Given this list of marker genes ELMO1 (NCBI Gene Id 9844), ZBTB18, TMEM127, SOX4, GPA33, OGA, AZI2, KMT5A, GTSF1, IL23A, VPS4B, ARHGAP1, TMEM100, TBC1D17, NOSTRIN, PYM1, PCED1A, COPS7A, MAP2K6 (mitogen-activated protein kinase kinase 6), SIPA1, EGFL7, ESRRA, NCKAP1L, APBA3, PPP3CB, ZCRB1, ZCCHC9, EIF3L, WDR53, ANKHD1, DPP3, FAM200A, TIMMDC1, ZSCAN31, MRPL54, CFAP57, R3HCC1L, RXRB, CRTC2, NMNAT1, PRPF4, LIFR, TRAPPC1, RPL28, CAST, CORO6, ANKS1A, GABRA1, THAP5, PAF1, HELZ2, FOXN3, TMUB2, CES2, PAK3, DGKZ, ITPKB, LZTFL1, PCSK5, PDE12, PTPRG, TLE4, FYN, SLC39A7, DLG2, LINC03124, BTBD16 (BTB domain containing 16), OLFM1, CAPZA1, PPP1CA, VASP, MTBP, ZFP3, KANSL1, CPEB4, UBXN1 (UBX domain protein 1), RASAL1, MAP4K2, AP4E1, GIT2, ZNF35, LZTS2, RHOJ, LTB4R, TRAF7, ZRANB2, TBCC, TBC1D10C, ZNFX1, ARHGDIB, CHN2, INTS3, TEAD3, PDLIM5, GMPR2, RHOV, ANKHD1-EIF4EBP3, WDFY4, CHMP1B, WAS, SMC6, SLITRK1, MTX2, POU3F4, LCP1 (NCBI Gene Id 3936), CNTROB, EN1, TCF7, UQCRH, KLF12, CRB3, POLD4, CCNT1, PSMA5, STARD13, CREBZF, SHC1, CNST, SYTL1, STK10, PACC1, FAM110A, ST7L, PHB2, PRKAG2, FAM174A, FNTA (farnesyltransferase, CAAX box, subunit alpha), CCDC71, DPP8 (NCBI Gene Id 54878), EVX1, ELP2, IRF2BP1, FEZF2, FBXL9P, ZCCHC7, EPHA2, DOK1, EIF4G1, TIE1 (tyrosine kinase with immunoglobulin like and EGF like domains 1), MTPN, PPHLN1 (NCBI Gene Id 51535), TRPC4AP, IFI30, ARHGAP30, RBMS2, LLGL2, TMEM208, MAPK14, NEDD8, HERPUD2, ACKR1 (atypical chemokine receptor 1 (Duffy blood group)), DDX55, ZNF205, ARPC4, EIF3K, LCK, NOVA1, MCTS1, NUDT21, TRAPPC11, LOXL3, ELK3, TBX6, HERC4 (NCBI Gene Id 63907), ANKH, MTERF1, POMP, ZNF408, TMEM161B, CLN5, HAT1, U2AF2, LANCL3, VCL, VPS16, ADCY2, SLC39A11, LZIC, CCAR2, LYL1, RAP2C, UBE2D3, INSIG2, CITED2, CBLB, PHC2, AKT1S1, TAF5, UFC1, ARHGEF6, ZBTB7B, CSF3, PPIG, USE1, CKS1B, CNOT6L, DBR1, TADA3, DDX1, LDOC1, RAC1, ACIN1, RWDD4, CD37, PRDM1, STAT4, TFB2M, SEMA4C, EBNA1BP2, SOST, CCDC88B, RELCH, TXLNG, FURIN, MAP4K1, ZNF593, NECAP2, DNAJB9, VPS11, SOX15, PLEKHH2, DMTF1, MRPL13, ARHGEF4, BCL2L1, SASH3 (NCBI Gene Id 93952), NUP155, NUDT22, SEC11A, DCAF1, SLC39A6, EMG1, CIAO1, STX5, PAX6, ITGB7, PRKAB1, SNIP1, SP3, PTPRN, PPME1, TNNI2, TAGLN2, NKAIN1, UTP18, RTL9, CDC26, PLXDC2, NR1H2, NDN, SH2D3C, RBM6, GGNBP2, LINC01565, SIRPA, LSM5, DSCAML1, SH2D6, ZNF70, WDR90, GEN1, DGKA, ENPP1, ADNP, CIAO2B, TRPT1 (NCBI Gene Id 93089), ZNF800, LRRC41, ZMYND8, IL7R, STX19, TGFBR2, FOS (Fos proto-oncogene, AP-1 transcription factor subunit), NR1D1, C14orf119, here is a description of the gene set: studied in species Homo sapiens Genes having at least one occurrence of the motif NAAACMGGAAGTNCVH in the regions spanning 4 kb centered on their transcription starting sites. This matches the ELK1 transcription factor binding site V$ELK1_01 (v7.4 TRANSFAC). Human Gene Set: ELK1_01